The following is a description of a gene set: species: Homo sapiens The process whose specific outcome is the progression of the thymus over time, from its formation to the mature structure. The thymus is a symmetric bi-lobed organ involved primarily in the differentiation of immature to mature T cells, with unique vascular, nervous, epithelial, and lymphoid cell components. Human Gene Set: GOBP_THYMUS_DEVELOPMENT, and this is the list of marker genes: MAP2K2, PSEN1, FOXN1, RAG1 (NCBI Gene Id 5896), SOD1, COA5, TBX1, CTC1, BCL2, BCL11B, EPHB3, ZBTB1, SLC46A2, TYR, TGFBR1, MAD1L1, ATM, LMO4, FGF10, MYB, CRKL, MAFB, SRF, GATA3, HES1, MAPK3, SHH, HOXA3, CITED2, RIPK3, BCL2L11, SIX1, MAPK1, BRAF, RAF1, ZMPSTE24, ASXL1, AIRE, PRDX2, PBX1, ABL1, HAND2, SIX4, CACNB4, FADD, MAP2K1, CCNB2, CTNNB1, FOXI3, FOXE1, JARID2